The following is a description of a gene set: A cellular component that consists of an indeterminate number of proteins or macromolecular complexes, organized into a regular, higher-order structure such as a polymer, sheet, network or a fiber. species: Homo sapiens Human Gene Set: GOCC_SUPRAMOLECULAR_COMPLEX, and this is the list of marker genes: TRIM32, ZFAND1, RASSF5, CHMP4BP1, CENPO, PDLIM1, PKP2, KLC1, TBCB, CIRBP, PDLIM3, DCPS, MISP, EDC3, CENPV, SCYGR3, KEAP1, ALDOA, FBXO28, PLK3, RAC2 (NCBI Gene Id 5880), KRTAP5-6, KRTAP10-4, KIF9, PIERCE2, PDLIM5, ZWINT, MAP6D1, FYN, COL4A5, NRP1, MARK2, PTPN20, PPL, SH2B2, LRWD1, HAUS8, MYH11, MYOZ2, CIMIP2B, TEKT5, MAEL, GRAMD2B, SLAIN1, KIF3C, COL11A1 (NCBI Gene Id 317718), TUBA3C, APC2, NOCT, AICDA, FKBP4, RC3H2 (NCBI Gene Id 54542), KRT72, NUF2, SCYGR6, KRT18 (NCBI Gene Id 3875), LSM1, CLIP2, FLG, KRTAP24-1, MX1, GRSF1 (G-rich RNA sequence binding factor 1), PABPC1, MX2 (NCBI Gene Id 4600), LARP1, SLMAP, CKAP5, FASTKD5, MYL12B, ARL3, PBXIP1, COL4A3, RAB3D, BIRC5, VCL, APOBEC3F, DCP1A, ANK3, LARP4B, KRTAP9-2, KRTAP20-1, COL6A2, MYOM3, SPTBN1, KRTAP13-2, COL8A1 (collagen type VIII alpha 1 chain), IGFN1, ADPRHL1, COL3A1, TUBA8, HOXD10, KRTAP20-2, KRT84, KRT86, TNNI1, RSPH1, SPECC1, SYNPO (NCBI Gene Id 11346), APOBEC3A, KPTN, MYH6, AGO3, SNCA, DNAH14, HJURP, DNM1, INVS, YBX1, DPYSL3, FRG1, CHMP1A, DLG1, LTBP1, TUBA4B, MBNL1, KIF11, TUBGCP2, MEFV, KIFC2, CHMP4B, KATNAL1, KRT8, LUM, DIAPH3, SMC1A, ARHGAP18, EIF4E2 (eukaryotic translation initiation factor 4E family member 2, NCBI Gene Id 9470), CUL3, TPPP2, GAS2, NCKAP5, CAMSAP3, KCNN2, TNNI3, ATXN2, SERPINB1, CIMAP1A, KIF5B, KIF20A, PPP6R2, DYNC1H1, MYH10, CLASP2, CNOT7, RP1, TMOD1, SCN1A, CLIP1, BUB3, TUFT1, TSC1, TUBB2A, DYNLT2, DCTN3, MYO6, TEKT1, TPM2, INA, STAU1, CTNNB1, TTL, KRTAP19-6, TARDBP, NEK7, SCTR, FEZ1, BRD7, MEX3B, KRTAP4-9, CORO1A, EVPL, GABARAPL1, ACTB, KCNAB2, WDR90, TBRG4 (transforming growth factor beta regulator 4), CLOCK, KANSL1 (KAT8 regulatory NSL complex subunit 1), KIF7 (kinesin family member 7), SNRPG, GHR, KMT5B, SNTB2, UBAP2L, CAPN3, DLGAP2, BOD1L2 (biorientation of chromosomes in cell division 1 like 2), CTSH, ASB2, CLTC, PYROXD1, MYL3, ARHGAP4, DAZAP2, COL6A3, DVL1, TUBGCP6, LIMD1, KRTAP15-1, KIF17, CD2AP, FAM110A, AVIL, CTSG, HSPH1, KRT9, STAU2, RYR1, MTMR12, ZNF207, CFAP68, KRT16, KCNJ8, ILK (integrin linked kinase), KRTAP4-16, RYR2, COL4A2, SAXO4, TUBA1C, EIF2S1, FKBP1B, TBCE, MYL9 (myosin light chain 9), SPMIP9, CSPP1, CDT1, DDX25, KRTAP6-2, ZFP36L1, CHMP4A, HOOK3, DISC1, KRTAP5-2, KRTAP22-2, UPF2, SCYGR1, KIF13A, KIF25, RASSF3, PRKD1, SPAG8, CENPN, KRTAP6-1, KRTAP9-1, MT3, NANOS3, SCYGR4, DNAI2, MYO3A, KRTAP9-4 (NCBI Gene Id 85280), KIF2A, HAUS4, MAPRE2, MAP1LC3A, TMOD2, PABPC4L, DHX36, ARF1, LSM4, GAS2L3, KRTAP2-1, TTLL1, BOD1, DDX19A, DES, ACTBL2, LRRC49, PHF2, PRRC2C, MAPRE1, FBXL22, TDRD6, DCX, SEPTIN2, COL11A2, MYBPC2, KRT31, MYL5, NICN1, CALD1, RAC1, DUSP22 (NCBI Gene Id 56940), POLB, PAN2, FAM161B, CFAP53, KRT74, ZW10 (zw10 kinetochore protein), CELF1, KRT75, TEX14, NUP160, KRT33B, CARMIL1, ACTN2, SGO2, CKAP2, FLNA, EIF4EBP2, CNOT9, DYNLL2, BARD1, RUSC1, TUBA1A, NUFIP2, DST, TRIM25, DDX1, PGM5, NDC80, SCYGR5, FBN1, PLK2, DCXR, RANGAP1, KCNN1, CSNK1D, AGO4, TUBG2, CIMAP1D, PARP4, CHMP6, HAUS7, ACTA2, ADAMTS10, ANXA1, CENPW, KCTD6, NYNRIN, MICAL1, SUGT1, SLC39A2, TCP11L1, SPC25, KRT34, ITGB1BP2, RCSD1, KRTAP23-1, NCKIPSD, CCT8 (chaperonin containing TCP1 subunit 8), APC, TRIM5, HOOK1, FHOD3, HAUS2, KIF13B, KATNB1, ATAT1, PDLIM2, C9orf72, SVIL, COL5A1, KRTAP13-4, KIF21A, MAP1LC3B2, RCC2, DCTN5, SPAG5, KRTAP10-12, GLRX3, PDE4DIP, SYNC, RMDN3, TEKTIP1, ZNFX1, NUSAP1, KRTAP9-7, BAG3, KRTAP4-8, HID1, MDM1, AJUBA, SPAST, INO80, MAP1B (NCBI Gene Id 4131), NUDC, PARVB, PRPH, SAMD4A, RASSF1, TDRD7, LARP1B, DYNC1LI2, KRT1, KAT8, RAC3, JUP, PECAM1, KRT38, PABPC5, KIF6, ACTL6B, AHNAK, STMN1, YTHDF3, OGFOD1, CHMP5, KRT82, WHAMM, KRTAP3-2, KRT12, PHF10, GABARAPL3, MYH8, SQSTM1, KIFC1, KRT73, GABPB1, SMPX, DNAH17, CENPU, DNAH7, PSMC3, CLMP, KNTC1, MYO18B, RMDN2, KRT87P, RAB11A, EML5 (EMAP like 5), MAP10, H3-3A, DHX9, CRHBP, KRTAP1-4, FHL2, CEP162, LSM2 (NCBI Gene Id 57819), DYRK3, UBAP2, HENMT1, TRIM63, FASTK, NCKAP1, KRT24, EML4, EIF4G1, ANK1, ASPM (NCBI Gene Id 93990), GAS8, CHAMP1, AURKC, DNAJB6, KRT71, NUP85, JAKMIP1, POLI, HSF1, SEPTIN9, CHMP2A, KRTAP10-2, KHNYN, PABPC4, CASP1, SDC4, DYNC1I2, KRT222, ACTG2, ACKR2, MFSD2A, DYNC2H1, DNAL1, TOGARAM1, SMARCC1 (SWI/SNF related, matrix associated, actin dependent regulator of chromatin subfamily c member 1), CIMIP2C, RPS6, NEFH, TNNT1, KIF23, OBSCN, DYNLT1, CACNA1C, KRT23, POLR2M, LSM14A, TUBGCP4, NBR1, EXD1, MYO9A, SHB, KRTAP9-6, LUZP1, KIF4B, KRT14, CENPS, MID1IP1, ARHGAP6, CENPX, TRPV4, FKRP, DMD, MTCL2, NUDCD2, PUM2, RGS14, APOBEC3C, DDX4, EPPK1, SAXO1, KRT33A, ANG, KLHL41, MAP2K2, CAPRIN1, MYL1, SMARCA4 (NCBI Gene Id 6597), EMD, DCDC2, TTLL13, RBM20, ZC3H12B, TUBB6 (NCBI Gene Id 84617), MYH15, KRTAP4-1, DPYSL2, SMARCC2, RACGAP1, TDRD9, ACTG1, MYH1, POTEJ, KRTAP5-11, BCL2L11, CENPC, UPP2, KRTAP4-11, CENPJ, UHMK1, CSRP3, RPS4X, CFAP20, KRTAP3-1, SSNA1, SCYGR7, RPTOR, KRT85, DCDC2B, SARM1, COTL1, CRYAB (crystallin alpha B), CENPE, LMOD1, BBLN, KRT3, CHMP2B, GGPS1, MAD2L1, DNAJA3, TOGARAM2, MYH4, DNAH11 (dynein axonemal heavy chain 11), JAM3, CHMP1B, MTUS2, BMP10, TBCD, KATNA1, TLK2, AFAP1, HAUS3, USP3, EFHC2, FLNB, SPMIP6, COL6A5, LSM3, MAPT, SNPH, DDX6, NANOS2, KIF2B, KIF12, DEK, LSM14B (NCBI Gene Id 51153), KRTAP21-3, PSRC1, TUBGCP3, KRTAP11-1, SMN2, ASZ1, AURKB, EDC4, KRT13, KRT36, KRTAP1-5, MTUS1 (NCBI Gene Id 57509), HAX1, SHROOM2, CNOT2, REC8, IFFO1, DNAH10, KRT27, CIMIP2A, BTBD1, TEKT3, EIF4ENIF1, HDAC6, MOV10L1, KRTAP10-6, KRTAP17-1, DCP1B, NAV3, KRT6C, CFAP52, KRT83, KRTAP12-1, KRTAP22-1, IDO1, NXF1, KRTAP5-7, KIF26A, CYP2A6 (cytochrome P450 family 2 subfamily A member 6), FHL5, PNRC1, C10orf71, CEP57L1, TRAPPC12, DYNC1LI1, HTR2A, OPA1, WDR47, ARID2 (AT-rich interaction domain 2), YTHDF2, KRTAP6-3, PSMA2, TDRD1, CTPS1, KRTAP19-5, PYCARD, REEP1, KLHL22, DDX28, KRTAP19-1, SMARCE1, MYPN, COL4A4, SMG1, KRTAP13-3, PSMA4, SYNJ1, KRTAP19-4, QKI, TPGS2, KRTAP5-8, GABARAP (GABA type A receptor-associated protein), GDPD2, CFDP1, NBDY, FXR1, FASTKD1, MAP1LC3C, FAM161A, SEC13, SAXO2, AGO2, HCK, CCNB1 (cyclin B1), CSDE1, DNAH8, TTLL8, TWF2, TSTD1, MYO18A, SMG5, ANKRD1, MYO1C, KRT40, KNL1, DNAH5, CSRP1, KCNN3, RBM4, COL10A1, SIN3A, KRTAP19-3, KIF22, KIF4A, MYOD1 (myogenic differentiation 1), ZNF804A, PSEN2, SPDL1, TIA1, COL4A1, MACF1, CDK5, TUBE1, HABP4, TPX2, FBLN1 (NCBI Gene Id 2192), HELZ2, CNOT3 (CCR4-NOT transcription complex subunit 3), APOBEC3H, MID2, GARRE1, COBL, DNAH12, PRKAA2, SCYGR2, POLR2G, MFAP5, LZTS2, NEFL, TUT4, ATP2B4, TUBG1, ESPN, LMAN1, MAP7D2, MYH14, HNRNPK, TPM1, MYL7, LMOD3, SNCAIP, SCYGR9, ZC3H12C, KIFC3, CORO1C, GRB7, DDX19B, XRN1, FMR1, TTLL5, NINL, KPNB1, CPEB1, COL28A1, KRTAP2-4, DYNC1I1, NAV1, KIF1C, PABPC1L, MYOM1, CFL2, TCP1, KRT76, NUP98, NDE1, FGF13, KCNE1, GJB6, KIF28P, TMEM214, SPTBN4, DDX3Y, PDLIM4, TTLL9, CCT5, LMNTD2, TNNT3, TMEM232, ANAPC16, KRT10, SMN1, SPECC1L, SYMPK, KIFAP3, DSP, S100A1, HELZ, SPAG17, SMARCD2, SKA1, DNM3, HOOK2, ABRA, TNK2, STIM1, HNRNPU, TTLL7, MAPRE3, PKP1, CAB39, PPP1R12B, DYNLL1, KRT6B, NDRG1, KIF2C, TPGS1, EFCAB6, MICAL2, EIF3B, IFT70B, G3BP1, EFHC1, PIWIL4, YTHDC2, MYBPC1, CFAP77, SLC1A4, POTEI, XPO1, ANKRD2, ATXN2L, SCO2, SRC, TDRD5, KRT17, KIF16B, HSPB1, PSMC2, MMP2, MFAP4, NRAP (NCBI Gene Id 4892), FBN2, ACTN4, KRT78, SAMD4B, MYZAP, AHCTF1, CAMSAP1, TRIM55, VCP, SGO1, CLIP4, KRTAP1-1, DNAH3, KIF15, ZAR1, NPNT, BTBD2 (BTB domain containing 2), NCKAP5L, JPH1, NEK6, FBN3, FLACC1, SCN8A, CENPL, CFAP107, SYBU, ACTN1, NUMA1, SIRT2, EFEMP2, SORBS2, NARF, DCTN1, SELENOS, BAG2, DCTN2, TIAL1, ARL6 (ADP ribosylation factor like GTPase 6), DNAI1, CFAP45, DUSP21, DNAH6, BPI, NSUN2, KRTAP5-5, TBCC, SCN3B, NDEL1, KIF18A, TTLL6, ACTA1, BFSP1, SLC4A1, CHMP4C, DNAH9, KRTAP19-7, TRIM21, MATCAP1, G3BP2, MAP1LC3B, SERP1 (NCBI Gene Id 27230), CDK5RAP3, ARC, SLAIN2 (NCBI Gene Id 80106), FMN1, DSN1, TUBA3E, MOV10, UNC45B, CFAP95, TEKTL1, KIF3B, APOBEC3B, EIF4E, MYBPC3, LCP1, SPOUT1, AURKA, TUBA3D, GIGYF2, SUMO1, JPH2, LDLRAP1, PAWR, KRTAP29-1, NOS1AP, SHROOM4, INF2, KRT37, LARP4, KRTAP4-4, ROCK1, KRTAP10-8, PNRC2, KRTAP10-7, KRTAP5-1, CNOT8, FIGN, EZR, MYL6B, CEP57, PHF6, KRTAP1-3, KRT15, EIF3A, KRT32, TNNI2, LSM6, KIF21B (NCBI Gene Id 54770), IQGAP2, MYL11, KRTAP8-1, NFKBIZ, IGF2BP1, TUBB3, CCT3, KRTAP10-11, CSRP2, PBRM1, PNN, FBXW11, APOBEC3G, MYH2, KRTAP10-1, DNAH2, PLS3, KRTAP19-2, KRTAP19-8, COL4A6, CCT6A, IQGAP1, SCN5A, H3-3B, COL1A2, TTK, KRTAP4-5, TNRC6C, MTCL1, RP1L1, LMOD2, CAPN6, TTLL4, CNOT1, ERCC6L, NSL1, NUP107, TMOD4, MYBPHL, CAPZB, RIBC2, SUMO3, ENKUR, TEKT2, MYO1B, AKNA, KRTAP7-1, OBSL1, TEK, MYO1A, BUB1, FBP2, LMNTD1, KRTAP20-3, PINX1, KRTAP13-1, MEX3A, LDB3, SEPTIN7, MAP2, KRTAP12-3, AKAP4, KIF27, CENPI, KRT77, COL2A1, KRTAP16-1, KRTAP10-10, PABPC3, BCAS3, KRT26, COL1A1, TCAP, TNRC6A, GFAP, AMOT, KRTAP12-4, DCDC2C, LMNA, CDK9, NUP43, AK1, PUM1, TAF5L, BLOC1S6, CTPS2, DPP9, TRIM54, MYO5A, ARHGEF25, CARHSP1, SAA1, MYOM2, SCYGR10, CFAP126, MYL2, KLC2, ZFP36, RBPMS, TTLL3, KRTAP5-10, KATNAL2, CNP, TPR, PRC1 (protein regulator of cytokinesis 1), MAP2K1, PQBP1, ABRAXAS2, DNM1L, CDK5R1, HAUS5, LMNB2, SEPTIN6, CDC20, CDK2AP2, KCNA5, TOP1, POTEF, MAP1S, RPLP0, LIMA1, TCHP, VPS18, CTTN, KLC3, ROCK2, SHTN1 (NCBI Gene Id 57698), IFFO2, KNSTRN, CYLD, RASSF2, TWF1, MTBP, CENPM, LRPPRC, THSD4, MEIKIN (meiotic kinetochore factor), KIF14, PPP3CB, KRTAP25-1, KRT5, COL6A1, PSMA6, CSNK1A1, CFAP141, CENPK, MAP1A, FAM110C, CMA1, PIERCE1, LIN28A, RPUSD3, DHX30, SMARCD1, PRICKLE4, MFAP1, CCSAP, ODAM, TNNC1, CBX5, REEP2 (NCBI Gene Id 51308), ODF2, TUBB2B, GAS2L2, DYNLT3, SKA3, KIF18B, POF1B, SARNP, KRT35, CASP14, KIF24, KRTAP10-9, FBXO32, CAV3, VMAC, CFAP90, CCT2, EML1, SRPRB, FXR2, PACRG, TMOD3, FERMT2, INCENP, TUBB, TPM4, MTA1, ENDOV, SYNE1, SYNE2, SLC2A1, KAT5, MFAP2, SRI, RC3H1, TTN (NCBI Gene Id 7847), FHDC1, PLS1, ZC3H12A, TEKT4, CENPT, KLHL21, KRTAP4-12, TRIM71, ABCC9, KAT2B, CCDC57, TUBB4B (NCBI Gene Id 10383), CFAP161, PLK5, PALLD, AMELX, ISG20, LRRC39, SHROOM1, CSTPP1, YES1, GPER1, ACTN3, CDK1, MYLK2, PPP3CA, BUB1B, COL5A2, CDK5RAP2, KRT28, DDX3X (DEAD-box helicase 3 X-linked), SPAG6, PABPC1L2A, REEP3, PAFAH1B1, LTBP4, DAG1, SEH1L, FAM83H, DNAH1, RYR3, ANKRD34C, KRT19, MYO9B, RBFOX1, ZWILCH, BFSP2, VIM, FBF1, PLK1, KRTAP27-1, MYL4, KRT79, IGF2BP3, KIF3A, KRT80, DNM2, NIN, HOMER1, STYXL2, KIF5A, KIF19 (kinesin family member 19), CFAP206, SHFL, TUBA4A, WHRN, MAP7, FBLN5, RNF135, PPP2R5A, CAMSAP2, GOLGA2, PDLIM7, KRTAP5-4 (NCBI Gene Id 387267), SMTNL1, ACTL8 (NCBI Gene Id 81569), HNRNPL, MYH9, KLC4, KRTAP2-3, TPPP, GTSE1, ZAR1L, TNNT2, DYRK1A, RMDN1, EML6, UPF1, MEAF6, SYNPO2L, PAN3, GPATCH11, PRP4K, RTN2, PABPC1L2B, TPM3, PIWIL3, SIMC1, ODF1, KRTAP3-3, TPPP3, PCBP1, RADIL, ADAMTSL5, PAK1, KIF26B, KRTAP9-9, NUP133, KIF5C, SPACA9, KIF1A, NUP37, KRT2, CACNA1D, EIF4A1, DMTN, RPUSD4, KIF20B, PVALEF, SS18L1, SNRPB2, FSD1, PPP1CC, SNRPGP15, TP53BP1, RPL6, HRC, KRTAP4-2, SPMIP11, BICD1, CASC3, CMYA5, KRTAP5-9, ITGB3BP, NEB, ATP2A1, HAUS6, TPT1, KRTAP26-1 (keratin associated protein 26-1), KRTAP5-3, TDRKH, ZNF276, APOBEC3D, FHL3, SKA2, TBCA, MYH3, RHOQ, ARFGEF2, NES, BCL10, CALM2 (NCBI Gene Id 805), FAM184A, CDC42, KRTAP21-2, DCP2 (NCBI Gene Id 167227), HAUS1, COL5A3, EML3, GTF2B, KRTAP20-4, NOS1, PARVA, PMF1, MIS12, AIF1L, CACNA1S, LRRC10, HLA-DRB1, KY, KRTAP10-5, ENKD1, CALM1, SCYGR8, MCRIP2, SSB, RPL28, CENPH, POTEKP, CFAP276, ADORA2A, MYH7, MYOZ3, CLDN11, HIPK2, ARPC3, MYH7B, POLDIP3, FASTKD3, KRT20 (keratin 20), CCDC66, DCTN4, TNRC6B, PIWIL2, MAP3K11, ZC3H12D (NCBI Gene Id 387078), MYH13, STUB1, TTLL11, ACTL6A, ANK2, KRT39, ACTC1, NEBL (nebulette), DNAJB4, TUBB8, KRT81, PPP1R12A, CEP295, IGF2BP2, KRT4, SPC24, NEK2, EIF6, MYOZ1, CFAP210, IFT70A, KRT7, COL27A1, WTIP, PSEN1 (NCBI Gene Id 5663), CFAP144, KRTAP21-1, GTSF1, MAD1L1, DIAPH2, CENPP, TUBB1, NME7, FKBP1A, POTEE, CCT7, EML2, CASQ1, PCNT, CEP170B (centrosomal protein 170B), SPEF1, AGO1, SMARCB1, KRTAP10-3, SCO1, TUBGCP5, PATL1, CEP170, EFHB, ELN, MTM1, WAS, PLEC, KRTAP12-2, KRTAP9-3, EID1, ENO1, MID1, CENPF, SYNM, ANKRD23, MAP6, TRUB2, TUBA1B, MAP9, CHMP7, CCDC181, TUBB4A, DNAL4, XIRP2, MCRIP1, ANKRD34B, TUBB8B, HNRNPAB, FBXO22, TNNC2, ABI2, ELAVL1, REM1 (RRAD and GEM like GTPase 1), KRTAP4-6, BMAL1, PDE4B, LMNB1, ANKRD34A, MYOT (NCBI Gene Id 9499), CHMP3, DYNLRB1 (dynein light chain roadblock-type 1), TUBD1, PATL2, ARHGEF2, DYNC2LI1, KLHL40, CENPQ, REEP4, SPRY2 (sprouty RTK signaling antagonist 2), KRTAP9-8, CALM3, FIRRM (NCBI Gene Id 55732), MAP4, MNS1, NEFM, KIF1B, DIS3L2, DIAPH1, NCL, BEX4, RIBC1, SHROOM3, SPMIP8, CAVIN4, SHANK2, SPMIP10, CCT4, ORC2, COL8A2, COL7A1, BAIAP2, COL6A6, CORO1B, PIWIL1, RBPMS2, KRTAP4-3, BIN1, SYNPO2, SLC8A1, DYNLRB2, KRT25, YTHDF1, KRT6A, DCTN6, APPBP2, WIPF1 (NCBI Gene Id 7456), CFAP96, CASQ2, TUBAL3, SLC8A3, FASTKD2 (FAST kinase domains 2), CLIP3, FLNC, NEXN, AIF1, GAS2L1, CLASP1, MYBPH, DCDC1, RNF4